Given this list of marker genes MIR17, CD300LF, IRF1 (interferon regulatory factor 1), S100A9, LRCH4, YWHAE, IRF4, LRRC14, NFKBIL1, TYRO3, GPR108, BIRC2, GPS2, CD300A, MIR19A, NLRP6, OTUD4 (OTU deubiquitinase 4), IRAK3, RNF115, GDI1, ESR1 (estrogen receptor 1), MIR146A, APP, CCDC134, MFHAS1, CD36, IRF7, LGR4, SMPDL3B, CACTIN (NCBI Gene Id 58536), HSP90B1, PDPK1, SARM1, IKBKB, ARRB2, NLRP2B, TASL, GFI1, S100A8 (S100 calcium binding protein A8), BIRC3, here is a description of the gene set: species: Homo sapiens Human Gene Set: GOBP_REGULATION_OF_TOLL_LIKE_RECEPTOR_SIGNALING_PATHWAY Any process that modulates the frequency, rate, or extent of toll-like receptor signaling pathway.